The following is a description of a gene set: Human Gene Set: GOBP_NEGATIVE_REGULATION_OF_ORGANIC_ACID_TRANSPORT studied in species Homo sapiens Any process that stops, prevents, or reduces the frequency, rate or extent of the directed movement of organic acids into, out of or within a cell, or between cells, by means of some agent such as a transporter or pore., and this is the list of marker genes: AKT2, FIS1, PRKG1, ACSL4, TRH, THBS1, AKT1, MIR33A, PLA2R1, GRM7, LEP, ADORA1, SLC43A1 (NCBI Gene Id 8501), GABBR1, CYP4F2, ARL6IP5, ABAT, IRS2, NPY5R, RGS2, TNF, SLC43A2, RGS4